Given this list of marker genes NSUN2, AP1G2, INSIG1, NRAS, SGCD, ZMIZ2, ANKRD44, SLC9A7, RAB8B (RAB8B, member RAS oncogene family), RNGTT, WSB1, USP25, MARCHF6, SEC16A, NFATC1 (NCBI Gene Id 4772), DHX15, LBR, ALCAM, DBF4, COX6C, SYNE2, FEM1A, EAF1 (ELL associated factor 1), PPP4R3B, TACC1, STARD4, BNIP3, NUP205, NOX4, PAG1, THOC7, RLF, APOA2, INTS7, CRIP2, LPP, DNAJA3, NMD3, HLA-DRB3 (major histocompatibility complex, class II, DR beta 3), G3BP2, SBNO1, SNX9, TAGAP, RNF213, ORAI2, FYTTD1, ANKRD20A1, SF1, TLE4, BCLAF1, C1orf159, PMAIP1, BET1L, KLHL15, LBH, STK4, PPTC7, GLCCI1, C12orf43, DNAJC5B, DDX49, STK10, ULK4, MUS81, C2CD5, SLC25A22, MIOS, AEN, PKD1, HOXA7, NR4A2, WDR75, PTPN11, EIF2AK3, PRKCI, IRS2, MED14, TCF7, CD164, PELI1, TAF1D, OGA, NFKBID (NFKB inhibitor delta), TRAK1, SCRN1, FMNL1, P2RY8, CRKL, AKR1D1, CD69, PTGER2, AGO2, KLRA1P (NCBI Gene Id 3819), UBR7, KLF10, ARL8B (NCBI Gene Id 55207), KBTBD8, SYNJ2, LIPA, SNRNP200, here is a description of the gene set: Human Gene Set: MODULE_261 species: Homo sapiens Genes in the cancer module 262.